The following is a description of a gene set: Human Gene Set: HP_ALOPECIA_TOTALIS Alopecia totalis species: Homo sapiens Loss of all scalp hair., and this is the list of marker genes: ZMPSTE24, GJB6, JUP, UQCRFS1, LSS, LMNA, RECQL4, ANAPC1, RIPK4, DSP, MBTPS2, NFKB2, ALX4, FOXN1